Given this list of marker genes Cdhr2, Pax2, Pnpla1, Bhlha15, Dab2 (disabled 2, mitogen-responsive phosphoprotein), Krt5, Nkx6-1, Cdh23, Reg3g, Robo4, Extl3, Gm5414, Nkx2-6, Ubiad1, Hdac1, Cdh5, Slc39a2, Krt16, Spry2, Cd63, Slc9a4, Psapl1, Dsp, Elf5, Spred3, Ppl, Ift20, Esr1, Hoxa5, Erbb4, Stat1, Krt26, Tlr9, Scx, Arhgef26, Ctnnb1, Rheb, Vhl, Mir7-2, Ajap1, Ceacam1, Mafb, Tmigd1, Smad3, Vsig1, Rock2, Krt24, Foxa3, Myo6, Wnt9a, Fat1, Spred2, Gdf3, Jag2, S1pr1, Arx, Add1, Cdkn2b, Fzd7, Cd109, Tgfb1, Mir375, Mef2c, Gsdma3, Mesp1, Mycl, Ush1c, Itga2, Ccdc88c, Adam7, Creb1, Upk2 (uroplakin 2), Stfa2, Gata6, Elmod3, Gdnf, Wdr72, Sox3, Intu, Magi1, Gdf7, Dmrt1, Tgfbr1 (transforming growth factor, beta receptor I), Il17a, Foxc1, Csta2, Hoxb13, Commd5, Cftr, Tagln2, Ttc8, Ophn1, Pdpn, Cnn3, Sprr3, Acta2, Krt23, Hapln2, Krt84, Acer1, Spink5, Tgm1, Skil, Pck2, Mir875, Atp2b2, Alox8, Tnfrsf1a, Kcnma1, Scel, Dspp (NCBI Gene Id 666279), Casp6, Ikbkb, Tyms, Notch2, Grhl2, Nkx2-2, Pax6, Xbp1 (X-box binding protein 1), Myo3b, Numa1, Myd88, Tie1, Rapgef2, Gli2, Men1, Exph5, Sox11, Pter, Krt32 (NCBI Gene Id 16670), Stfa2l1, Tgfb1i1, Pck1, Ces1e, Cdkn1b, Vim, Vil1, Nfkbiz, Pitx3, Pinc (pregnancy induced noncoding RNA), Cdkn2a, Anxa4, Stat5a, Bfsp2, Tmem100, Magi2, Iqgap1, Krt39, Grxcr2, Ift74, Ar, Krt73, Adamtsl4, Errfi1, Krt42, Ctsb, Bmp6, Wnt5a, Krt1, Psap, Fst, Mtss1, Lbh, Casp3 (NCBI Gene Id 12367), Rab13, Id2, Mir541, Gprc5d, Ggt1, Plcb1, Clcn2, Ppp3r1, Prox1, Hrh2, Nppc, Safb2, Ces1h, Slc9a2, Hdac2, Nkx3-2, Krt75, Foxe3 (forkhead box E3), Plaur, Ccno, Strc, Krt82, Fgf20, Ipo7, Ppp1r16b, Hes5, Myo1e, Gmnc, Nkx2-1, Yap1, Abcb1b, Adipoq, Hydin, Rfx3, Serpine1, Kcnq1, Cryaa, Bccip, Foxj1, Six2, Ptgs2, Csta1, Wt1, Cstdc4, Tcf15, Cdk6, Prok2, Mir96, Nherf1, Slc4a5 (NCBI Gene Id 232156), Nme2, Cstdc5, Kras, Cldn5, Sec24b, Sgpp1, Myadm, Krt15, Tgfb2, Jun, Macroh2a1, Krt86, Pcdh15, Madcam1, Grxcr1, Cdh3, Tbx1, Krt90, Smarcb1, Sdc1, Klf5, Kcne1, Thra, Ccm2, Tdrd7, Tprn, Krt74, Marveld2, Gpat4, Afdn, Nfib, Sipa1l3, Cnmd, Pou3f2, Med1, Nr5a2, Spry1, Map3k1, Ctsl, Ihh, Vezf1, Zdhhc7, Krt6b, Mmp9, Bmpr1a, Loricrin, Krt35, Map7, Nfe2l1, Met, Krt2, Kdm2a (lysine (K)-specific demethylase 2A), Nphs2, Nr5a1, Tubb5, Spred1, Tagln, Ntrk3, Krt81, Stc1, Cav1, Src, Mcidas, Rab25, Cep152, Cdh2, Dmd, Dnph1, Esrp1, Deup1, Ces1d, Cux1, Edn1, Smad4, Spint2, Bdh2, Krt85, Msx1, Tsg101, S1pr3, Gcm2, Npr2, Sprr2g, Eppk1, Cstdc3, Sprr2e, Krt9, Rac1, Aldoc, Fzd5 (frizzled class receptor 5), Lhx3, Wdpcp, Krt77, Krt27, Esr2, Plk4, Upk1a, Clic5, Tjp2, Fasn, Flnb, Bad, Gfi1, Tfcp2l1, Tmem231 (transmembrane protein 231), Wnt4, Cyp26b1, Fgfr2, Dnase1l2, Sprr2k, Zfp36, Plaat3, Six3, Crygd (NCBI Gene Id 27311), Il1a, Onecut1, Abcb1a, Fndc3b, Chrd, Dlg5, Foxb1, E2f7, Lta4h, Nphs1, Krt7, Btg1, F2rl1, Sprr1b, Nf2, Gata1, Crb3, Krt33a, Podxl (podocalyxin-like), Cd34, Ces1f, Fgfr1, Nr2f2, Gsdme, Bmp5, Acvrl1, Tnf, Krt87, Ptch1, Ptpro, Cdh1, Sfn, Ctnnd1 (catenin delta 1), Wnt10b, Xdh (NCBI Gene Id 22436), Slc44a4, Spdef, Fosl2, Il1b, Csf1r, Trp63, Thrb, S1pr2, Akr1b1, Fam3c, Foxn1, Kazn, Icam1, Hsd17b4, Sprr2f, Palld, Ntrk1, Sox2, Vax1, Nkx6-3, Pih1d1, Atf4, Maff, Bfsp1, Pparg, Ntf5, Fshr, Wnt16, Lif, Cd2ap, Pdpk1, Ptch2, Adrm1, Bmpr2, Fndc3a, Foxc2, Krt6a, Slitrk6, Clrn1 (clarin 1), Sox17, Dsg2, Fem1b, Smarca4 (NCBI Gene Id 20586), Sod1, Cbfa2t2, Col4a1, Dicer1, Asah1, Il6st, Pou3f1, Mir450b, Rab10, Muc2, Bcr, Mir214, Vcl, Hhex, Tjp1, Rarg, Tollip, Tjp3, Lipa, Rptor, Cgn, Pdzd7, Pof1b, Vdr (vitamin D (1,25-dihydroxyvitamin D3) receptor), Wwtr1, Tmem132e, Pax4, Whrn, Stx2, Dsg4, Lef1, Foxl2, Ccnd1, Sox4, Ncoa3 (NCBI Gene Id 99361), Rbpj (NCBI Gene Id 791349), Ubn1, Krt78, Zdhhc21, Csta3, Percc1, Smo, Basp1, Msi1, Sprr2d, Dll1, Tnmd, Nkx2-5, Bmal1, Fgfr3 (fibroblast growth factor receptor 3), Krt79, Krt83, Msx2, Smad2, Crhr1, Wdr77, Rbbp9, Ptprs, Pou2f3, Emx1 (empty spiracles homeobox 1), Krt14, Lhfpl5, Gpr4, Cldn1, Ptgs1, Ugcg, Mir874, E2f4, Kdm6b, Macroh2a2, Lats2, Hes1, Lce1g, Crygb, Taf10, Pgr, Sidt2, Krt25, Krt40, Foxp3, Pcna, Triobp, Otx2 (NCBI Gene Id 218991), Krt28, Prdm1, Crhr2, Id1, Flna, Sh3bp1, Trp73, Fzd1, Tbc1d20, Dlx6 (distal-less homeobox 6), Zeb1, Etv4, Gata2, Sall1, Ext1, Wnt9b, Lamb2, Krt72, Fn3k, Agr2, Zfp36l1, Pbrm1, Mafg, Foxa2, Col18a1, Cebpa, Wnt11, Kdf1, Dmbt1, Scrib, Hpse, Tbx3, Txnip, Pecam1, Notch4, Six1, Arid4a, Reg1, C1galt1, Etv2, Rest, Rhoa, Clrn2, Atoh1, Rapgef3, Skint1, Proc, Nup210l, B9d1, Hoxa13, Plec, Prkx, Ahi1, Evpl, Gak, Myo9a, Hoxb5, Ovol2, Sox8, Col6a1, Klf4, Fzd2, Map1b, Cep63, Stfa3, Zfas1, Amotl2, Hif1a, Gsdmc2, Neurod1, Ncor2, Cdx2, Frs2, Sox9, Nrg1, Ces1b, E2f8, Ift88, Ezr (ezrin), Krt17, Pelo, Tst, Ier3ip1, Ces1a, Pax8, Otp, Rock1, Acadvl, Kdr, Lce1a2, Ascl1, Klf2, Gm5478, Insm1, Keap1, Igf1, Sult2b1, Stfa1, Cps1, Asxl1, Cyp27b1, Slc4a7, Fgf8, Foxi3, Reg3a, Alg10b, Inhba, Fzd4, Yipf6, Foxa1, Ndp, Fat4, Tigar, Krtap6-5, Osr1, Krt76, Pkhd1, Pde2a, Frzb, Pthlh, Gata5, Ednra, Abca12, Rapgef1, Tmod1, Mir203, Fa2h, Frmd6, Ren1, Sharpin, Pdgfb, Maf, Spag6l, St14, Pgk1, Syne4 (NCBI Gene Id 76258), Akap9, Rilpl2, Enam, Tpp1, Prom1, Rfx6, Sprr1a, Sostdc1, Lamc1, Barx1, Krt4, Rbm4, Ankrd24, Sprr2h, Ezh2 (NCBI Gene Id 14056), Grhl1, Ercc2, Wnt1, Lats1, Hnf1b, Fer, Tmem38b, Jag1, Ehf, Vdac1, Clic4, Pls1, Bcl11b, Sult1b1, Rdx, Foxj2, Kdm5b, Pkp1 (NCBI Gene Id 98390), Pde4d, Il31ra, Tgm3, Krt31, Nodal, Cd24a, Zfp703, Myo7a, Gja1, Upk3a, Ercc3, Gata3, Nrbp1, Notch1, Rap1a, Gdf2, Hoxa7, Mcoln3, Slc7a11, Hsf4, Ampd2, Foxf1, Gstk1, Rilpl1, Sprr2b, Gli1, Ccdc78, Stk4, Gpx1 (glutathione peroxidase 1), Krt80, Dhcr7, Ift80, Cldn3, Ush2a, Epb41l5, Pafah1b1, Epas1, Dlx5, Apold1, Gata4, Ptk6, Ppp3ca, Epha2, Tfap2a, Cebpb (CCAAT/enhancer binding protein beta), Map2k1, Cstdc6, Ovol3, Krt20, Krt34, Krt10, Cited1, Prkch, Zfp800, Ces1g, B4galt1, Krt71 (NCBI Gene Id 56735), Rnase10, Cdkn1a, Ripor2, Hrnr, Krt19, Atoh8, Shroom3, Fgf10, Stat5b, Msn, Aimp2, Fgf2, Ros1, Ces1c, Clock, Krt13, Onecut2, Acvr1, Rarb, Abi2, Nkx6-2, Pard3, Prlr, Sav1, Plaat1, Cyp1a1, Plod3 (procollagen-lysine, 2-oxoglutarate 5-dioxygenase 3), Cnfn, Tcf21, Heg1, Cdkn1c, Cpt1a, Myo3a, Cdk1, Flvcr2, Grem1, Jmjd1c, Klf7, Nr0b1, Sprr4, Cdsn, Cdc42, Foxh1, Ifng, Sfrp4, Tecta, Cxcr4, Luzp1, Anxa1, Cers3, Tomt, Foxp4, Hey2, Hey1, Ivl, Rap1b, Fam20c, Mir205 (NCBI Gene Id 387201), Foxp1, Tmc1, Pphln1, Mir7-1, Lama1, Camsap3, Bmp2, Arid4b, Bmp7, Sox18, Mycn, Ascl5, Zeb2, Acvr2b, Cul7, Rara, Bmp4, Dlx3, Apc (APC, WNT signaling pathway regulator), Abl2, Id3, Pdx1, Abl1, Rap2c, Agt, Klf15, Krt33b, Opn3, Sprr2i, Ptprq, Minar2, Rxra, Ptk7 (PTK7 protein tyrosine kinase 7), Upk1b, Pou4f3 (NCBI Gene Id 240237), Krt12, Lhx1, Atrx, Dact2, Fstl1, Akap11, Irf6 (interferon regulatory factor 6), Ovol1, Tmem79, Neurog3, Fzr1, Gdf11, Mir503, Ednrb, Vegfa, Tfap2c, F11r, Krt36, Srsf6, here is a description of the gene set: studied in species Mus musculus The process in which a relatively unspecialized cell acquires specialized features of an epithelial cell, any of the cells making up an epithelium. Mouse Gene Set: GOBP_EPITHELIAL_CELL_DIFFERENTIATION